The following is a description of a gene set: Genes predicted to be targets of miRBase v22 microRNA hsa-miR-11181-5p in miRDB v6.0 with MirTarget v4 prediction scores > 80 (high confidence targets). Human Gene Set: MIR11181_5P from publication Chen Y, Wang X (PMID 31504780) species: Homo sapiens, and this is the list of marker genes: IGF1R, DNAJC3, GRPEL1, TMED1, F13A1, PID1, KCNS1, MTOR, EMCN, CREBRF, MTFR1, CHL1, EEIG2, GREB1, USP14, YIPF4, GLG1, SYCP2L, C9orf43, PWWP2A, MDN1, WDR47, ZC3H12A, C2orf49, ZFHX4, MITF, CLSTN1, ITGA10, MAP3K1, PIM2, ID2, MTF1, FHIP2A, SUSD4, ZNF385B, HNF1B, NEK6, CSTF2, KLF3, CMPK1, ARMC8, ICA1L, NUDT4, JKAMP, UBE2D3, FGD6, NFATC2, NR2C1, SGMS2, DENND11, FAM110C, TMEM263, HDDC3 (HD domain containing 3), WNK3, MCAM, CREB5, SORT1, FAM117B, DAZL, ABCC1, TIAM2, KIF14, ZNF831, MCM9, STX16, GNAI3, CEP126, HTR7, SNX4, IRAK3, IL6, PEX7